Given this list of marker genes TGFB1, STAT3, IL6, LIN28B, BMP4, here is a description of the gene set: species: Homo sapiens Any process that modulates the frequency, rate or extent of primary microRNA processing. Human Gene Set: GOBP_REGULATION_OF_PRIMARY_MIRNA_PROCESSING